Given this list of marker genes Pcnx1, Map3k9, Gm6722 (predicted gene 6722), Gm5436, Gm45930, Pnma1, Smoc1, Npc2, Mir3067, 4930423C22Rik, Acot2, 4933436F18Rik, Gm3693, Gm4787, Lin52, Ylpm1, Vrtn (NCBI Gene Id 432677), Slc10a1, Gm3791, Fcf1, Dcaf4, Bbof1, Gm18592, Rnf113a2 (ring finger protein 113A2), Pgf, Eif2b2, Adam21, Acyp1, Rps6kl1, Vsx2, Riox1, Med6, Gm31513, Rgs6, Dnal1 (dynein, axonemal, light chain 1), Acot6, Gm24853, Synj2bp, Mideas, 1700085C21Rik, Adam4, Gm46367, Zfp410, Nek9, Prox2, Entpd5, Gm22149, Papln, Ptgr2, Gm5435, Ltbp2, Numb, Coq6, Dpf3, Gm29530, Acot1, Mlh3, Abcd4, Gm8358, Gm3695 (predicted gene 3695), Arel1, Aldh6a1, Cox16, Mir6938, Rbm25, Syndig1l, 4732463B04Rik (NCBI Gene Id 100038552), S2bpcox16, Hspe1-ps2, Ttc9, 4930423D22Rik, Zfyve1, Heatr4, Gm46369, Fam161b, Gm19327, Acot3, Acot5, Gm16570, 1700030I03Rik, Isca2, Zc2hc1c, Gm8385, D030025P21Rik, Psen1, Slc8a3 (NCBI Gene Id 20543), Sipa1l1, Dlst, 6530401F13Rik, Gm49366, Acot4, here is a description of the gene set: studied in species Mus musculus Mouse Gene Set: chr12D1